Given this list of marker genes Mfrp, Srsf11, B3gnt3, Psmd7, Fads1, Frem3, Map3k8 (NCBI Gene Id 26410), Sdccag8, Nfasc, Krtap6-5, Ada, Slc13a1, Efr3b, Trim21, Ly6g, Apob, Adamts20, Kremen1, Etf1, Csf1r, Pah, Mrpl54, Tpbpa, Cul1, Cplx1, Slc37a3, Extl2, Irag1, Kcnn3, Nemp2, Cfl1, Dcun1d3, Shh, Ugt3a2, Hnrnpu, Adam17, Cfap141, Lap3, Steap4, Stum, Arhgap28, Dpy30 (dpy-30, histone methyltransferase complex regulatory subunit), Dimt1, Wfikkn2, Prl3b1, Ddx21, Psd3, Dbndd2, Krtap2-20, Ciao1, Vmn1r71, Nckap1l, Pcdh7, Zfp418, Ago3, Spn, Bco1, Foxp2, Rnf150, Trim30a, Gm9, Cklf, Klf6, Hectd4 (HECT domain E3 ubiquitin protein ligase 4), Aftph, Aak1, Gigyf2, Hdlbp, Stau2, Eri2, Eeig2, Or7d10, Lbp, Bfsp1, here is a description of the gene set: Mouse Gene Set: MIR_493_3P Genes predicted to be targets of miRBase v22 microRNA mmu_miR_493_3p in miRDB v6.0 with MirTarget v4 prediction scores > 80 (high confidence targets). from publication Chen Y, Wang X (PMID 31504780) species: Mus musculus